Given this list of marker genes Cdkn2c, Hmgn1, Ret, Men1, Braf, Nf1, Pten, Rb1, Dkc1, here is a description of the gene set: studied in species Mus musculus Mouse Gene Set: MP_INCREASED_PHEOCHROMOCYTOMA_INCIDENCE from publication Motenko H, Neuhauser SB, O'Keefe M, Richardson JE (PMID 26092688) Mouse genes annotated to increased pheochromocytoma incidence (MP:0002050) retrieved from the Mouse Genome Informatics database via MouseMine